Given this list of marker genes CNST, CAV3, GJA5, CXADR, SRC, here is a description of the gene set: Human Gene Set: GOMF_CONNEXIN_BINDING Binding to a connexin, any of a group of related proteins that assemble to form gap junctions. studied in species Homo sapiens